The following is a description of a gene set: Blood vessel formation when new vessels emerge from the proliferation of pre-existing blood vessels and contribute to the series of events that restore integrity to a damaged tissue, following an injury. species: Mus musculus Mouse Gene Set: GOBP_ANGIOGENESIS_INVOLVED_IN_WOUND_HEALING, and this is the list of marker genes: Cd34, Smoc2, Stard13, Gata2, Npr2, Vegfa, Gpr4, Ndnf, Tafa5, Foxc2, Slc12a2, Vegfb, Cx3cl1, Adipor2, Dag1, Kdr, Mcam, Gpx1, Alox5, Hif1a, B4galt1, Hpse, Xbp1 (X-box binding protein 1), Prcp (NCBI Gene Id 72461), Serpine1, Cxcr4, Tnf, Pik3cb (phosphatidylinositol-4,5-bisphosphate 3-kinase catalytic subunit beta)